Given this list of marker genes TGFB1, TGFBR2, here is a description of the gene set: species: Homo sapiens The short adenine repeat in the coding sequence of TGF-beta receptor II (TGFBR2) gene is frequently targeted by loss-of-function frameshift mutations in colon cancers with microsatellite instability (MSI). The 1- or 2-bp deletions in the adenine stretch of TGFBR2 cDNA introduce a premature stop codon that leads to degradation of the majority of mutant transcripts through nonsense-mediated decay or to production of a truncated TGFBR2 that cannot be presented on the cell surface. Cells that harbor TGFBR2 MSI frameshift mutations are resistant to TGF-beta (TGFB1)-mediated growth inhibition. Reactome Pathway: TGFBR2 MSI Frameshift Mutants in Cancer part of: Loss of Function of TGFBR2 in Cancer